The following is a description of a gene set: from publication Wei G, Wei L, Zhu J, Zang C, Hu-Li J, Yao Z, Cui K, Kanno Y, Roh TY, Watford WT, Schones DE, Peng W, Sun HW, Paul WE, O'Shea JJ, Zhao K (PMID 19144320) Genes down-regulated in comparison of Th1 cells versus natural regulatory T cell (Treg). Human Gene Set: GSE14308_TH1_VS_NATURAL_TREG_DN studied in species Homo sapiens Multipotential naïve CD4+ T cells differentiate into distinct lineages including T helper 1 (Th1), Th2, Th17, and inducible T regulatory (iTreg) cells. The remarkable diversity of CD4+ T cells begs the question whether the observed changes reflect terminal differentiation with heritable epigenetic modifications or plasticity in T cell responses. We generated genome-wide histone H3 lysine 4 (H3K4) and lysine 27 (H3K27) trimethylation maps in naïve, Th1, Th2, Th17, iTreg, and natural (n)Treg cells. We found that although modifications of signature cytokine genes (Ifng, Il4, and Il17) partially conform to the expectation of lineage commitment, critical transcription factors such as Tbx21 exhibit a broad spectrum of epigenetic states, consistent with our demonstration of T-bet and IFN-gamma induction in nTreg cells. Our data suggest an epigenetic mechanism underlying the specificity and plasticity of effector and regulatory T cells and also provide a framework for understanding complexity of CD4+ T helper cell differentiation., and this is the list of marker genes: GSK3B, FRMD4A, GALNT4, GPS2, RHOT1, SLF2, TOP2B, BEX2, PAM, FBXO10, TMEM30B, IL2RB, BTBD9 (BTB domain containing 9), CALCRL, VPS13B, MTMR3, CREG1, NADK, TBL1X, GNRHR, UCKL1, HAUS3, CBFA2T2 (NCBI Gene Id 9139), TM9SF2, RBL1, RIN3, KANSL1, ADIPOR2, KLHL12, PAN2, TCAIM, ZBTB2, HAO2, C2CD5, TGIF2, USP32, IL10RA, DDX11, LUC7L3 (LUC7 like 3 pre-mRNA splicing factor), ADH1C, ZNF692, KCMF1 (potassium channel modulatory factor 1), CAD, ESS2, C12orf56, ADPRH, TMCC1, RCCD1, TIAM2, DMAC2L, SLC22A5, TGFBRAP1, LSP1, RBBP5, DNAJC28, DDX5, SCN2B, TARS2, KCNH2, EIF2B4, XXYLT1, ATXN7, FSD2, LRRC20, HLA-E, DTX4, WDFY2, KDM5B, PAPOLG, SIPA1L3, CALU, HACD4, ALDH4A1, KERA, CRTAM (NCBI Gene Id 56253), C19orf33, CYB5R3, PPM1L, HIBADH (3-hydroxyisobutyrate dehydrogenase), SLC34A3, GPR174, PIGT (NCBI Gene Id 94004), CREBL2 (NCBI Gene Id 1389), CDIP1, MEDAG, COQ6, FHIP2B, STARD5, HNRNPC, VPS26A, ROCK1, MIGA1, GABRR2, MFN2, PLCG1, PNCK (pregnancy up-regulated nonubiquitous CaM kinase), ATXN2L, ANKRD13B, CNR2, GOSR2, HSD17B14 (hydroxysteroid 17-beta dehydrogenase 14), EXT1, ARHGEF1, TEF, SLC1A5, CPLANE1, CXXC5, EXT2, ZNF764, TFCP2, SPRED1, TRPC4AP, GLYCTK, TCHP, ANGEL1, AMFR, NBR1, BAZ2B, ERBB3, KMT2E, HLCS, PITHD1 (NCBI Gene Id 96276), FAM13B, AXIN1, GRIK2, TRMT6, TBX6, DPEP1, ZDHHC15 (NCBI Gene Id 158866), TDRD7, RNF44, LY6D, SLC36A4, EML3, NSFL1C, SCMH1, AFF1, CD3E, BMP7, PIP5K1B, BCL2L15, COG3, RAMP1, ARB2A, FREY1, ARHGAP45, BRD9, MTMR9, C2orf76, CEP164, MAPK7 (NCBI Gene Id 5598), SVIL, BSDC1, ARNT, ZBTB26, SPIN1, ORC5, FABP7, SLC8B1, ZBTB48, ASAP2, GADL1, PPP2R2A, FAM50A, TXN2, FRMD6, OSBPL11, RNF19A, NFATC1, DNAJA4, VPS9D1, LPXN, LTO1, PDE2A, GGA2, ARMCX2, DDX50, PPIG, NINJ1, TMTC3, STAU1, DERL1, SEMA4C, VPS39, TCN2, ARFGEF2, IRF1 (interferon regulatory factor 1), ATF6B, CBX6, TMIGD1, CIAPIN1, TNRC6C, PTPRCAP, PHETA2, RAP1GDS1, TTI1, PEX11A, IL1RN, ZFP28